Given this list of marker genes Hcn3, Rapgef4, Mpp4 (NCBI Gene Id 227157), Pclo, Slc32a1, here is a description of the gene set: A specialized axon terminus which is produced by retinal cone cells. Pedicles are large, conical, flat end-feet (8-10 micrometers diameter) of the retinal cone axon that lie more or less side by side on the same plane at the outer edge of the outer plexiform layer (OPL). studied in species Mus musculus Mouse Gene Set: GOCC_CONE_CELL_PEDICLE